Given this list of marker genes Tbx20, Rbm27, Slc16a9, Clstn2, Sntg1, Ppp2r3d, Wdr26, Phkb, Pcdhb11, Ugcg, Eif4h, Pate14, Dock7, Tmem185b, Mycbp2, Zc3h11a, Gng2, Hapstr1, Zic3, 1700102P08Rik, Odf2l, Tdrd12, Skida1 (SKI/DACH domain containing 1), Gabra4, Snx25, Slc35f6, Phactr1, Ackr3, Actrt3, Ttc13, Slc10a5, here is a description of the gene set: Mouse Gene Set: MIR_218_2_3P species: Mus musculus from publication Chen Y, Wang X (PMID 31504780) Genes predicted to be targets of miRBase v22 microRNA mmu_miR_218_2_3p in miRDB v6.0 with MirTarget v4 prediction scores > 80 (high confidence targets).